Given this list of marker genes MRAS, ESAM, DEPDC5, POLR1A, CCDC22, COL5A1 (NCBI Gene Id 1289), SNAI2, NAA10, TRAF7, FBN1, RASA2, MLXIPL, MMP21, ZEB2, DVL3, LIMK1, SKIC2, NODAL, NOTCH2 (notch receptor 2), FGFR1, LMNA (lamin A/C), CRTAP, TYR, RPL10, VPS37D, BRD4, TGFBR1, CEP295, GPC6, STX1A, KRAS, PLXND1, AGGF1, BMPR2, NKX2-6, ODAD1, PPP1CB, GATA6, MYH7, IFT43, UBE2A, BGN, EOGT, DOCK6, EIF4H, TLL1, FOXF1, RIT1, TMEM270, DLK1, IFT56 (intraflagellar transport 56), FKBP6, TCIRG1, LZTR1, TMEM94, SOX10, ESS2, MED12, CCNQ, ARSL, AASS, NCF1, GDF1, CLCN7, FADD, GTF2I, BCOR, SOS1, PKD1L1, MITF, LTBP4, BAZ1B, TBL2 (NCBI Gene Id 27203), ELN, GATA4, NKX2-5, ITPR1, CBL, ARHGAP31, TBX1, NRAS, RFC2, ALDH1A2, SKIC3, CNTN1, TRAIP, ACVR2B (NCBI Gene Id 93), EDNRB, MGP, FBLN5, SOS2, TGFBR2, WRN (WRN RecQ like helicase), DNAJC30, PLD1, BCL11B, SPRED2, BRAF, KITLG, TAOK1, WNT4, SLC2A10, DGCR8, POLA1, FLT4, GTF2IRD2 (GTF2I repeat domain containing 2), PIGL, ADAMTS19 (NCBI Gene Id 171019), CIROP, GTF2IRD1, LIFR (NCBI Gene Id 3977), DGCR6, METTL27, CHD7, STRA6, RRAS2, PIK3CA, RRAS (RAS related), RTL1, JAG1, ACTA2, PAX6, PIGO, OTUD5, DGCR2, TNFSF11, BUD23, COL3A1, NOTCH1, CRELD1, B3GLCT, IPO8, DLL4, RAF1, SMARCA4, SNX10, RBPJ, CLIP2, LTBP1, PIGN, FRA10AC1, MEG3, PTPN11, SMG8, ALDH18A1, EFEMP2, here is a description of the gene set: An abnormality of the pulmonary artery. Human Gene Set: HP_ABNORMALITY_OF_THE_PULMONARY_ARTERY studied in species Homo sapiens Abnormality of the pulmonary artery